The following is a description of a gene set: Individuals with 22q11.2 microdeletions show behavioral and cognitive deficits and are at high risk of developing schizophrenia. We analyzed an engineered mouse strain carrying a chromosomal deficiency spanning a segment syntenic to the human 22q11.2 locus. We uncovered a previously unknown alteration in the biogenesis of microRNAs (miRNAs) and identified a subset of brain miRNAs affected by the microdeletion. We provide evidence that the abnormal miRNA biogenesis emerges because of haploinsufficiency of the Dgcr8 gene, which encodes an RNA-binding moiety of the 'microprocessor' complex and contributes to the behavioral and neuronal deficits associated with the 22q11.2 microdeletion. Genes up-regulated in hyppocampus of mice carrying a hemizygotic microdeletion in the 22q11.2 region. studied in species Mus musculus Human Gene Set: STARK_HYPPOCAMPUS_22Q11_DELETION_UP from publication Stark KL, Xu B, Bagchi A, Lai WS, Liu H, Hsu R, Wan X, Pavlidis P, Mills AA, Karayiorgou M, Gogos JA (PMID 18469815), and this is the list of marker genes: FBXW11, EFR3A, YWHAG, ST3GAL2, GPD1L, PAPOLA, GRK2, CLEC16A, RCC2, SORT1, CX3CL1, CNNM1, EPAS1, TRAK1, TFRC, PEAK1, DLG2, MTMR4, RPH3A, PCNX1, ATP6V0A1, ATP13A2, UVRAG, AP2A2, USP7, CNTNAP1, GRIN2B (NCBI Gene Id 2904), SPIN1, OLFML2B, RAB6B, NETO1, MIR22HG, DCLK1, IDS, AAK1 (AP2 associated kinase 1), SLC17A7, MIR9-2HG, EMC10, VAMP2, HNRNPU, MIR29B2, B4GALT6, CAMKK2, AOPEP, CDK5R1, BSN, FJX1, B3GAT1, MIRLET7A3, GPR68, KBTBD11, ZNF445, CPEB4, STXBP1